Given this list of marker genes HPS4, GPR143, ATP6AP2, SPNS2, TYR, IHH, here is a description of the gene set: Establishment of a pattern of pigment in the eye of an organism. Human Gene Set: GOBP_EYE_PIGMENTATION species: Homo sapiens